The following is a description of a gene set: Human Gene Set: NKX2_8_TARGET_GENES studied in species Homo sapiens from publication Yevshin I, Sharipov R, Kolmykov S, Kondrakhin Y, Kolpakov F (PMID 30445619) Genes containing one or more binding sites for (NKX2-8) in their promoter regions (TSS -1000,+100 bp) as identified by GTRD version 20.06 ChIP-seq harmonization., and this is the list of marker genes: MDGA1, COL4A3, ATG101, RBPJL, GPRIN2, KDM5A, DGAT2-DT, FBXL12, DNAJA4, CDCA7L, COL4A4, CCDC77, EWSR1 (EWS RNA binding protein 1), FBXO33, RPL10P15 (ribosomal protein L10 pseudogene 15), ANXA2, MYCBP2-AS1, USP15, SYNC, TC2N, HNF4A, SRI, YWHAZ, SNORA70, R3HDML-AS1, RNF38, RHBDD3 (NCBI Gene Id 25807), WASF2, LINC01342, FAM53C, MYL12-AS1, AHNAK, CPSF3, MYL12B, NDUFB1, PPP5D1P, DNAJA4-DT, ITGB1BP1, CALM3, TAFA2, DGAT2, CPSF2